Given this list of marker genes MTFR2, CLEC10A, MPRIP, FAS, ZNF692, HERC1, MTHFD1L, IDH2, RHOA, C17orf58, DHRS3, SPIDR, LIFR, SSNA1, TTL (NCBI Gene Id 150465), FAM167A, KIAA0930, HDAC11, RPH3AL, SLC2A3, SEMA4B, WDR25, TRAF3, ADA, ACCS, GABARAPL1, PAN2, TECPR2, COX6A2, CD7, TRMT2A, CTNS, TTYH3, DAP, BCL3, TK1, MIEN1, CLCN5, PHC1, RRBP1, INTS13, CNPPD1, HABP4, STAP1, ZNF512B, SLCO4A1, DNAL4, CCDC137, DENND5A, GOT1L1, VMAC, DUSP4 (NCBI Gene Id 1846), DDX19B, GOLGB1, SAYSD1, SLC4A11, TBC1D9B, DDB2, ZNF512, CCDC115, SLC2A4RG, CD68, GSTM4, PHF5A, FAH, PPM1F, SERPINB1, HNRNPUL2, MLX, GPRC5B, WBP1, SEPTIN11, COTL1, CHD3, TMEM26, SELENOH, CISD3, XBP1, SLC41A2, PMM1, DIABLO, FAM234A, SNAP29, SEC31A, TEX48, DMPK, B4GALNT1, LAMTOR2 (late endosomal/lysosomal adaptor, MAPK and MTOR activator 2), MMP11, DYNLT1, HDDC3, NBN, KLHL14, SAMSN1, DNTT, PANX1, CAP1, LIPC, ZW10, DHX29, EGFL6, PARP4, ZNF25, CALR, IFT140, CAMTA1, FAHD2A, C8orf58, PPP1R12B, GSTM5, MACO1, GLYR1, MEAK7, PLCG1, CEP89, RGS19, VASP, PPP1R21, PCP4, C8A, CD40, GNPDA1, SEPTIN4 (septin 4), LAIR1, CHTF8, LONP2, SLC22A15, KDM4A (NCBI Gene Id 9682), UBR5, PGRMC2, RALGDS, SPRED2, HDAC6, TCHP, HAGHL, WDFY2, RASSF4, KCNQ5, KLHDC9, CCNB2, VAMP1, LGALSL, GUSB, PDRG1, CHST7, HIGD2A, BID, MAN1C1, TMEM161A, NRM, LTA, DNAJC9, KRT222, ERG28, UBAP2L, H2AX, GRHPR, KCTD13, MLLT6, FMNL3, ADSS1, SETD1B, GGA3, ALOX5AP, ZNF638, NUCB2, ATP1B1, ATP6AP1, RASGRP3, SPTAN1, BBS9, ILK, CDC42BPG, RND3, ATIC, STING1, CHKB, CDC25B (cell division cycle 25B), BHLHE40, NXF1, LMAN2L, DCTN6, DENND6B, SIPA1L2, LXN, FLNA, ALG2, SERAC1, KRTCAP3, C1orf159, CCNY, AMPD3, CTSV (NCBI Gene Id 1515), CFP (complement factor properdin), SCLY, ITGB7, GOLM2, AHI1, TRIP6, PHF2, here is a description of the gene set: from publication Takata H, Naruto T, Takiguchi M (PMID 22174157) species: Homo sapiens Genes down-regulated in effector CD8 T cells: CXCR1+ versus CXCR1-. Effector CD8+ T cells are believed to be terminally differentiated cells having cytotoxic activity and the ability to produce effector cytokines such as INF-γ and TNF-α. We investigated the difference between CXCR1+ and CXCR1- subsets of human effector CD27-CD28-CD8+ T cells. Both subsets similarly expressed cytolytic molecules and exerted substantial cytolytic activity, whereas only the CXCR1- subset had IL-2 productivity and self-proliferative activity and was more resistant to cell death than the CXCR1+ subset. These differences were explained by the specific up-regulation of CAMK4, SPRY2, and IL-7R in the CXCR1- subset and that of pro-apoptotic DAPK1 in the CXCR1+ subset. The IL-2 producers were more frequently found in the IL-7R+ subset of the CXCR1- effector CD8+ T cells than in the IL-7R- subset. IL-7/IL-7R signaling promoted cell survival only in the CXCR1- subset. The present study has highlighted a novel subset of effector CD8+ T cells producing IL-2 and suggests the importance of this subset in the homeostasis of effector CD8+ T cells. Human Gene Set: GSE26890_CXCR1_NEG_VS_POS_EFFECTOR_CD8_TCELL_DN